Given this list of marker genes MT1X, MT1F, MT1H, MT1E, MT1G, MT1M, MT2A, MT1A, here is a description of the gene set: from publication Richert L, Hue S, Hocini H, Raimbault M, Lacabaratz C, Surenaud M, Wiedemann A, Tisserand P, Durier C, Salmon D, Lelièvre JD, Chêne G, Thiébaut R, Lévy Y, ANRS Vaccine Network/Vaccine Research Institute (PMID 23759749) Genes up-regulated in peripheral blood mononuclear cell stimulated vs unstimulated in adults (37-48) after exposure to HIV-LIPO-5, time point 0W and 14 W. Comment: metallothionein genes, 0W and 14W combined (identical signatures) OBJECTIVE: To dissect the biological mechanisms involved in the cellular responses to a candidate vaccine containing 5 HIV peptides coupled to a palmytoil tail (HIV-LIPO-5) in healthy volunteers, by using extensive immunogenicity assessments with different stimulation durations. DESIGN: Immunogenicity substudy of a randomized phase II prophylactic HIV vaccine trial (ANRS VAC 18). METHODS: HIV-LIPO-5 or placebo was administered at W0, W4, W12 and W24. Peripheral blood mononuclear cells from a subset of participants at W0 and W14 were stimulated with HIV-LIPO-5, Gag peptides contained in the vaccine and control peptides. ELISpot, lymphoproliferation, intracellular cytokine staining (ICS), cytokine multiplex and transcriptomic analyses were performed. Different time points and stimulation conditions were compared, controlling for test multiplicity. RESULTS: Cultured ELISpot and lymphoproliferation responses were detected at W14. Ex-vivo ICS showed mainly interleukin (IL)-2-producing cells. Secretion of interferon (IFN)-gamma, tumour necrosis factor (TNF)-alpha, IL-5 and IL-13 increased significantly after culture and Gag stimulation at W14 compared to W0. Metallothionein genes were consistently overexpressed after HIV-LIPO-5 stimulation at W0 and W14. At W14, significant probes increased substantially, including IFN-gamma, CXCL9, IL2RA, TNFAIP6, CCL3L1 and IL-6. Canonical pathway analyses indicated a role of interferon signalling genes in response to HIV-LIPO-5. CONCLUSION: HIV-LIPO-5 vaccination elicited Th1 and Th2 memory precursor responses and a consistent modulation in gene expression. The response profile before vaccination suggests an adjuvant effect of the lipid tail of HIV-LIPO-5. Our combined immunogenicity analyses allowed to identify a specific signature profile of HIV-LIPO-5 and indicate that HIV-LIPO-5 could be further developed as a prime in heterologous prime-boost strategies. species: Homo sapiens Human Gene Set: RICHERT_PBMC_HIV_LIPO_5_AGE_37_48YO_STIMULATED_VS_UNSTIMULATED_0W_14W_METALLOTHIONEIN_SUBSET_UP